The following is a description of a gene set: Any process that activates or increases the frequency, rate, or extent of leukocyte chemotaxis. studied in species Mus musculus Mouse Gene Set: GOBP_POSITIVE_REGULATION_OF_LEUKOCYTE_CHEMOTAXIS, and this is the list of marker genes: Ccr1, C5ar1 (complement component 5a receptor 1), Spi1, Calr, Tnfsf14, Ccl19-ps6, Cxcl12, Il23a, Dnm1l, Adam17, Ccr7, Dysf, Ccr6, Swap70, Stk39, Nckap1l, Tirap, Ano6, Ccl21a, Mdk, Camk1d, Mstn, Ptprj, Wnk1, Cx3cl1, Csf1, Cxcl17, Tmem102, Sell, Ptk2, Thbs4, Il12a, Ccl5, Lgmn, Mapk1, Cxcr2, Tnfsf18, C1qbp, Fpr2, Cx3cr1, Ppbp, Pgf, Trem1, Rarres2 (NCBI Gene Id 71660), Hmgb1, Ccl21f, Ednra, Ccr2, Edn2, Akirin1, Cd74, Aif1, Ccr1l1, C3ar1, Ccl19-ps3, Mcu, Serpine1, BC037156, Cxcl13, Perp, Ccl21b, Dapk2, Ccl1, F7, Nedd9, Ccl7, Pla2g7, Fpr-rs4, Vegfa, Edn1, Mospd2, S100a14, Il34, Vegfc, Ptk2b, Il4, Cxcl10, Edn3, Rac1, Gas6, Ccl3, Oxsr1, Lbp, Ccl21e, Zfp580, Ptn, Cxcl14, Wnt5a, Ccl19-ps5, Ripor2, Thbs1, Ccl19, Ccl2, Il1b, Vegfb, App, Ccl21d, Ccl19-ps4, Rac2, Fpr-rs3 (formyl peptide receptor, related sequence 3), Defb25, Trpv4, Adam10, Xcl1, Fpr-rs7, Fpr-rs6, Mapk3, Vegfd, Cmklr1, Slamf1, F2rl1, Creb3, Ccl19-ps1, Csf1r, Gpsm3